Given this list of marker genes Ank1, Fbxw2, Farp1, Yy2, Sh3pxd2a, Camk1d, C1qtnf1, Mal2, Fstl5, Ankrd44, Fyco1, Smg1, Isg20l2, Traf3, Samd9l, Gad1, Cd247, Dlg2, Hdhd5, Braf, Nalcn, Nr4a3, Ifit2 (interferon-induced protein with tetratricopeptide repeats 2), Kif5b, Cables1, Slc35g2 (NCBI Gene Id 633413), Cavin3, Tex55, Plxna2, Cacnb4, Rftn1, Cdc14b, Zik1 (NCBI Gene Id 22775), Bmp2k, Arih1, here is a description of the gene set: from publication Chen Y, Wang X (PMID 31504780) Mouse Gene Set: MIR_3076_3P species: Mus musculus Genes predicted to be targets of miRBase v22 microRNA mmu_miR_3076_3p in miRDB v6.0 with MirTarget v4 prediction scores > 80 (high confidence targets).